The following is a description of a gene set: species: Mus musculus Mouse Gene Set: GOBP_NEGATIVE_REGULATION_OF_CELL_CYCLE Any process that stops, prevents or reduces the rate or extent of progression through the cell cycle., and this is the list of marker genes: Mre11a, Bcl2, Babam1, Fam107a, Cdc5lrt7, Orc1, Taok1, Rgcc, Mad2l1, Nle1, Aven, Baz1b, Bub3, Trim35, Npm1, Cry1, Ptprk, Zwilch, Poc5, Trip13, H2-M3, Nudt6, Tipin, Hsf1, Zfp207, Nppc, Mir26a-1, Ccnb1-ps, Setmar, Wac, Syf2, Tpr, Hexim2, Pinx1, Adcyap1 (NCBI Gene Id 11516), Foxn3, Cul4a, Chek1, Mir26b, Cdkn1a, Nabp1, Zfp830, Mus81, Wee2, Ints3, Brinp3, Bard1, Psmg2, Foxo4, Rfwd3, Lif, Rad51, Ppp2r3d, Sin3b, Tfap4, Rnaseh2b, Inca1, H2ax, Tmsb4x, Egfr, Pml, Ccng1, Taok2, Tnks, Brd7, Mdc1, E2f1, Dtl, Abraxas1, Atrip, Lats2, Bub1, Dgkz, Kank2, Tent5b, Mos, Cdk6, Zfp36l2 (NCBI Gene Id 12193), Bmp7, Sirt1, Chek2, Gigyf2, Ptprv, Dna2, Eme1, Rbbp8, Bmp2, Ier3, Susd2 (NCBI Gene Id 71733), Plk3, Foxk1, Men1, Rbl2, Sde2, Rad50, Fbxo4, Zfy2, Lyn, Rad1, Rps6, Rad9a, Aurka, Ik, Prkaca, Aurkb, Nek2, Mbd4, Tex14 (NCBI Gene Id 97747), Xrcc3, Prpf4b, Creb3l1, Dtx3l, Dync1li1, Stk33, Chmp2a, Prpf19, Kat2b, Khdc3, Klf4, Atf2, Mettl13, Diaph3, Wdr76, Ppp1r13b, Cdt1, Cdkn2a, Fem1b, Spc24, E2f8, Tiprl, Lcmt1 (leucine carboxyl methyltransferase 1), Apbb2, Nbn, Heca, Cdc14b, Inhba, Cdk5rap2, Foxc1, Nr4a1, Brca2, Blm, Pkd2, Kntc1, Usp28, Ctnnb1, Fbxo7, Kifc1, Tnf, Dusp1, Mdm1, Cdca8, Nme6, Naa10, Tom1l1, Parp9, Donson (NCBI Gene Id 68649), Ska1, Tom1l2, Zfyve19, Znhit1, Acvr1, Rbl1, Zwint, Dlg1, Cdkn1b, Arhgap33os, Alox8, Prkacb, Gjc2, Hus1b, Trp53, Apc (APC, WNT signaling pathway regulator), Btn2a2, Ctdspl, Rrp8, Tpra1, Xpc, Cdkn2b, Cdc5lrt4, Chtf18, Ctdsp1, Mbtps2, Prkdc, Cdk5rap1, Birc5, Mtbp, Topbp1, Fgfr3, Ccnb1, Vps4a, Atr, Cdc5lrt10, Runx3, Cdc5lrt9 (cell division cycle 5 like, retrotransposed 9), Brca1, Trex1, Cdc5lrt1, Pcid2, Atm, Anapc15, Fhl1, Myo16, Rad9b, Cdc5l, Cts7, Ets1, Mad1l1, Brd4, Gnb1l, Slfn1 (NCBI Gene Id 20555), Chmp4c, Hus1, Cebpa, Smarca5, Uimc1, Rb1, Ska3, Bub1b, Rpa2 (replication protein A2), Kat2a, Nek11, Osm, Suv39h1, Rhob, Ovol1, Spc25, Cdkn1c, Wee1, Mad2l1bp, Klhl22, Plk1, Plaat3, Mov10l1, Pkmyt1, Brcc3dc, Zw10, Crlf3, Mcidas, Stk38, Pabir1, Zc3h12d, Scrib, Clock, Rps27l, Brcc3, Wapl, Gen1, Tti1, Ufl1, Nupr2, Fzd3 (frizzled class receptor 3), Ercc6, Ctdsp2, Rint1, Rbm46, Map3k20, Hnf4a, Anapc15-ps, Fzr1, Znrf4, Cenatac, Gata3, Cdk5rap3, Tsc22d2, Tnfaip3, Ppp1r10, Pten, Gas1, Rad17, Cdc73, Sox2, Ints7, Meioc, Dab2ip, Ccnd1, Gpnmb, Btg4, Prox1, Spdl1, Zfp36l1, Epm2a, Cdc5lrt5, Timp2, Nherf1 (NHERF family PDZ scaffold protein 1), Cdkn2c, Hormad1, Cdk5, Tgfb1, Nubp1, Lats1, Cep192, Trim39, Etaa1, Clspn, Mir26a-2, Nae1, Mrnip, Recql4, Nabp2, Cdc5lrt6, Timeless, Miip, Dcun1d3, Nupr1, Gmnn, Nanos2, Cdc20, Knl1, Myocd, D7Ertd443e, Fancd2, Brinp1 (NCBI Gene Id 56710), Trrap, Prap1, Angel2, Cdk1, Hpgd, Rps6ka2, Trp53bp1 (NCBI Gene Id 27223), Pdik1l, Brinp2, Mbtps1, Eme2, Dmrt1, Ccar2, Ccl12, Fbxo5, Tmem67, Gpr15lg, Ticrr, Casp3, Mapk12 (mitogen-activated protein kinase 12), Fbxo31, Ttk, Fbxo43, Rhno1, Ezh2, Mapk14, Ndc80, Rnf167, Prmt2 (NCBI Gene Id 50502), Cdkn2d, Rbm14, Mfn2, Cdc5lrt8, Rpl24, Cdc6, Cenpe, Nuf2, Nr2f2, Brsk1, Eif2ak4, Bmp4 (bone morphogenetic protein 4), Trp53i13, Dyrk1a, Apbb1, Gmnc, Atf5, Ptpn3, Npr2, Atrx, Hinfp, Gper1, Cdk2ap2, Ptpn11 (protein tyrosine phosphatase, non-receptor type 11), Hhex, Incenp, Dot1l, Esr1, Babam2, Stk35, Apbb3, Ccnf, Cacnb4, Ppp2r5b, Fgfr2, Taf6, Btg3, Usp44, Ythdc2, Inip, Nop53, Jade1, Usp47, Haspin, Trim37, Rad21, Grb14, Dact1, Nsun2, Nek1, Abl1, Msh2, Zfp655, Ptgs2, Chfr, Macroh2a1, Gpr132, Stil, E2f7, Cep63, Mir214, Taok3